Given this list of marker genes TUT7, TDRKH, BRIP1, NPM2 (NCBI Gene Id 286056), SERPINA5, QKI, CCNB1IP1, SLC22A14, SEPTIN14, SPACA6, SUFU, CELF1, SPPL2C, SYCP3, PAQR8, NANOS2, RSPH1, FZD4, SPINK2, NEURL1, EED, TNP2, STK33, MLH1, STRBP, FOLR2, BCL2L1, LYZL4, SRC, SPATA46, PTCH1, PMFBP1, ZPBP2 (NCBI Gene Id 124626), DNHD1, FANCG, IHO1, TMEM95, KAT5, BCL2, RARA, SEBOX, MEIOSIN, ZNF830, YTHDF2, SOHLH1, NOX5, TSSK6 (NCBI Gene Id 92970, testis specific serine kinase 6), GDF9, LRRC46, BMPR1B, DCST2, TDRD6, POC1B (NCBI Gene Id 91413), BAX, HEXB, FOLR1, EFCAB9, OOSP2, PLN, FAM9B, TBC1D20, TSSK3, SPDYA, KAT8 (NCBI Gene Id 88034), MDK, RIMBP3C, KLC3, ZBTB16, DPY19L2P2, DEAF1 (DEAF1 transcription factor), NECTIN2, DYNLL1, TMPRSS12, DPY19L2, IFT81, ZFP57, BNC1, WEE2, KASH5, GARIN1A, RIMBP3B, AGFG1, MSH2, REC8, CFAP54, ZP3, ATM, SLC26A6, FNDC3A, GMCL2, TSSK1B, CEP128, DNAH1, CATSPER2, METTL3, YIF1B, LYZL6, SPACA3, GK2, PRMT7, CCDC159, PDE3A, SPACA1, KLHL10, FXR1, ARID4B, TSSK4, MAJIN (membrane anchored junction protein), RBM46, FUT6, BRCA2, CFAP97D1, C2CD6, SPO11, NPR2, DAZL, CFAP221, SIX5, KNL1, ARID4A, SPEF2, JAM3, PDCL2, CCDC42, RNF17, MYCN, KIT, MAST2, TTLL1, TMF1, GALNTL5 (polypeptide N-acetylgalactosaminyltransferase like 5), NPHP1, EQTN, SEMG2 (semenogelin 2), SHB, UBE2J1, CFAP157, IQCF1, ANGPT2, CFAP44, CDYL, MKKS, DND1, EREG, PIWIL2 (NCBI Gene Id 55124), ZMYND15, EIF4G3, ADGRG2, UBE2B, CFTR, DRC1, SOHLH2, WDR54, MFSD14A, SUN5, NANOS3, FAM9A, GARIN4, FER, NUP210L, SYCP1, PAQR7, TDRD5, PIK3CA, FMN2, AKAP4, EHMT2, ACTL7A, RAN, ZGLP1, TPGS1, STRA8, NME5, GLIPR1L1, NOBOX, LIN28A, CRISP1, DNMT3A, IGF2, SEPTIN4, ROPN1, BBOF1, SIRT2, REC114, H2BC1, PACRG (parkin coregulated), CATSPER3, CABYR, PDILT, RXFP2, TDRD12, CCDC63, SPATA16, ANG (NCBI Gene Id 283), PITHD1 (NCBI Gene Id 96276), ARMC12, CATSPERZ, ETV5, TARBP2, CFAP52, GSK3A, SOX30, PYGO1, SPEM3, DHH, FSHR, AURKA, BCAS2, DMRT1, STAU2, SRPK1, FOXL2, TERB2, PRDM1, TUBA8, IQCG, RIMBP3, INHBB, TUBB8, CEP131, VPS13B, PRM1, CTNNB1, ZMYND12, SPEM1, DDX4, PYGO2, RHBDD1, ERCC1, CFAP53, CCDC38, RFX2, SMAD5, JAM2, TTLL5, FOXO3, ZAR1L, MOV10L1, PTX3, C16orf92, CFAP69, SPACDR, PANX1, SBF1, SLIRP, BMP4, SPAG16, NPPC, AKT1, ZAR1, TDRD7, MARF1, KDM3A, CFAP65, IFT56, H1-7, RNF8, H1-9P, CDC25B, NANOS1, CFAP57, EDNRA, DMRTC2 (NCBI Gene Id 63946), ROPN1L, CTCFL, TAF4B, YTHDC1, ADAM2, YBX2, PLA2G3, BBS4, RETN, PAQR5, GPR149, NDN, CHN2, CFAP58, CCDC62, ZFY, SELENOF, FIGLA, ARMC3, CATSPER4, IGF1, H3-3B (H3.3 histone B), PRKACA, PIWIL1, AXDND1, FBXO5, TCP11X2, TBPL1, TRIP13, MNS1, NSUN2, PPP2R1A, CELF4, CCDC146, CCDC136, PSME4, EPC1, KIAA0319L, CAPZA3, OSBP2, CCR6, TMEM119, WDR77, INHBA, SPAG17, ELSPBP1, PCSK4, FSIP2 (fibrous sheath interacting protein 2), VPS54, LSM14B, DCAF13, MTA2, PTN, BRDT, BSPH1, SPAG6, SLC9A8, IHH, TUT4, TBC1D21, MEIOC, DZIP1, PANK2, FREY1 (Frey regulator of sperm-oocyte fusion 1), ING2, CFAP61, AGFG2, TDRD1, HMGB2, WASHC5, DNMT3L, RNF2, DCAF17, FBXW11, SPACA5, GMCL1, FOLR3, HORMAD1, GARIN3, DDX20, TCP11 (NCBI Gene Id 6954), TTC21A, ADAD2, CFAP119, PRDM14, ROPN1B, CATSPERE, HOOK1, EDN1, CIB1, NODAL, ACTL9 (NCBI Gene Id 284382), DDX6, SPAM1, SPINK1, YTHDC2, PAFAH1B1, SPANXB1, ADAM7, DDX25, PLD6, CHD5, TSSK2, CCER1, DCST1, CDKN1C (NCBI Gene Id 702), ABHD2, RPS6KB1, ICA1L, MECP2, SLC26A3, ADAD1, FAM9C, TNFAIP6, ADCY10, MEI4, DEFB1, DIAPH2, ZPBP, TNP1, LLCFC1, TCP11X1, IZUMO1, VDAC3 (NCBI Gene Id 7419), BBS2, WT1, ASPM, SPESP1, MOS, MEIG1 (NCBI Gene Id 649987), CD9, PAEP, ACVR1, CYLC1, CATSPERD, MCMDC2, PRM2, ARMC2, DLD, SEMG1, KDM1B, ZDBF2, CFAP47, OCA2, DRC7, KMT2D, RSPH6A, CTCF, CFAP206, PRKG1, DMC1, MTOR, C14orf39, DIRAS3, IQCN, RPS6KA2, TRIM28, LGR5, IZUMO1R, CFAP43, PFN4 (profilin family member 4), CCNB1, CEP57, ACRBP, H3-3A, SMARCA2, GLI1, ADGB, IZUMO3, AFF4, TTC12, DNALI1, RAB24, TPST2, AMH, HSPA2, SPACA5B (sperm acrosome associated 5B), WNT4, GARIN1B (golgi associated RAB2 interactor 1B), STAU1 (NCBI Gene Id 6780), here is a description of the gene set: A process, occurring at the cellular level, that is involved in the reproductive function of a multicellular organism. Human Gene Set: GOBP_CELLULAR_PROCESS_INVOLVED_IN_REPRODUCTION_IN_MULTICELLULAR_ORGANISM studied in species Homo sapiens